The following is a description of a gene set: Genes having at least one occurrence of the motif ANANTTTTATKRCC in the regions spanning 4 kb centered on their transcription starting sites. This matches the CDX2 transcription factor binding site V$CDX2_Q5 (v7.4 TRANSFAC). species: Homo sapiens Human Gene Set: CDX2_Q5, and this is the list of marker genes: PCSK1 (NCBI Gene Id 5122), IRX4, HOXC10, H3-3B, LSAMP, CCDC68, PRDM1, AOC1, CHST2, LEPROT, NR6A1, SUMO4, NCOR1, FSIP2, ROBO1, SSBP3, TRERF1, TSC22D1, ZFPM2, PDZRN4, PPP1R12A, NKRF, MBTPS2, LRP2, JAG1, ELP4, DCHS1, CHMP2B, PCDH7, NMT1, SERTAD4, INS, CASC2, DYNC1LI1, NFIB, HOXB3, MTFR1L, TLE4, PMF1, CCER1, MBD5, ARX, CLTC (NCBI Gene Id 9511), RAX, TTC12, ECM2 (extracellular matrix protein 2), ENSG00000291228, TWIST1, POU3F3, PLSCR4, ADCYAP1, HOXC4, POFUT1, HECTD2, MEIS1, NAV3, TASP1, FOXN3, HOXC12, ATP5MC2, ATXN7L1, FRMD5, HMGA2, KCTD15, ADAMTSL1, NRXN1, GRIK3, IKZF2, BACH2, SOX4, HOXA2, ASB2, GAD1, GMPR, CYB561D1, HOXD3, TOB1, CADM1, TRIM2, LHX6, SLC13A1, CPS1, MN1, NME3, PLAG1, PCF11, AGBL4, NTF3, PIK3R3, VLDLR, WNT8B, ANGPT1, NEO1, MBNL2, CTTNBP2NL, EREG, ELAVL2, NREP, PAX1, RPL38, SESTD1, ARL4A, HOXD9, SLIT3, SRPK2, LMO3, TMOD4, NPVF, ENSG00000255537, KIAA1549L, IGSF22 (NCBI Gene Id 283284), GPATCH11, PPARGC1A, IL1RAPL1, FOXA2, SKIDA1, VWA7, RALYL, IRX6, AMOT, MAP2K1, PNRC1, LINC00670, HOXA9, LEPR, SLF2, PHF21A, ZMYM4, CABCOCO1, FOXP1, BNC2, MBNL1, HOXB6 (homeobox B6), MLLT3, HOXC6, RPE65, RIMS2, DTNA, PHOX2B (paired like homeobox 2B), SKP1, RGN, SYTL2, ELK3, ZIC4, CXCL13, DMD, LOX, CACNA1C, TRMT112, TEKT3 (tektin 3), HTN1, SOX14, DLG2, HNRNPA0, ADAM11, CYRIA, PRDX5, TMEM126B, MARCHF3, NID2, CHCHD7, NDRG3, TSPYL2, HMBOX1, KRT20, CBFA2T2, CTAGE4, LPL, SI, UBR3, PLPP7, PCSK2, DPYD, ATP13A4, FAM91A1, PNMA1, ZRANB1, TAB3, ARB2A, NCKAP5, WDR47, CFL2, LCOR, DVL2, HOXA7, C1QTNF7, VANGL1, ASIC5 (NCBI Gene Id 51802), MAP2K5, NDUFA4L2, SMAD1 (SMAD family member 1), DCAKD, PTPRR, PAX6, SEZ6, PLAGL2, CDAN1, HOXA3, RTL10, TCF21, ALDH1A2, AP1S2, EPHA7, CER1, KCTD4, TNFRSF17, PTH1R, IMMP1L, DARS1, XPO7, LUC7L, ZNF362, POU4F2, INPPL1, DPF3, PTGES2, TBX5, TBL1XR1, SBSPON, IFIH1, ZBTB10, NKX6-1, BMI1, NRP1, KDM6A, ANP32D, PDAP1, CEP15, MNT, POU4F3, MEIS2, PDE6D, BBS1, RRM2B, UBE2C, CNTLN, HSD3B7, DAAM1, PRPH, RNASEH2C, CCDC92, LRCH1, HOXA11, SCML1, KRT36, ELAVL4, FOXD3, WSB2 (NCBI Gene Id 55884), MMP7, AGR3, CREB5 (NCBI Gene Id 9586), STAG1, PAPPA, VIT, NHLH2 (NCBI Gene Id 90888), SNAP25, DLX1, MRFAP1, BTK, LY6G6E, GCG, GNB1L, KIF1C